The following is a description of a gene set: Human Gene Set: HAY_BONE_MARROW_CD34_POS_GRAN species: Homo sapiens from publication Hay SB, Ferchen K, Chetal K, Grimes HL, Salomonis N (PMID 30243574), and this is the list of marker genes: HGF, SH3D21 (SH3 domain containing 21), TMEM258, MPO, VAT1, P4HB, GPR12, C1QTNF4 (C1q and TNF related 4), NPW, CTSG, HSPB1 (heat shock protein family B (small) member 1), SNORC, ERLIN1, CEACAM6, ELANE, PLPPR3, SUCNR1, MIF, CLEC11A, PRTN3, SNHG19, AZU1, CALR, PRSS57, RNASE3, CPA3, STAR